The following is a description of a gene set: Genes with promoters bound by FOXP3 in unstimulated hybridoma cells. Foxp3+CD4+CD25+ regulatory T (T(reg)) cells are essential for the prevention of autoimmunity. T(reg) cells have an attenuated cytokine response to T-cell receptor stimulation, and can suppress the proliferation and effector function of neighbouring T cells. The forkhead transcription factor Foxp3 (forkhead box P3) is selectively expressed in T(reg) cells, is required for T(reg) development and function, and is sufficient to induce a T(reg) phenotype in conventional CD4+CD25- T cells. Mutations in Foxp3 cause severe, multi-organ autoimmunity in both human and mouse. FOXP3 can cooperate in a DNA-binding complex with NFAT (nuclear factor of activated T cells) to regulate the transcription of several known target genes. However, the global set of genes regulated directly by Foxp3 is not known and consequently, how this transcription factor controls the gene expression programme for T(reg) function is not understood. Here we identify Foxp3 target genes and report that many of these are key modulators of T-cell activation and function. Remarkably, the predominant, although not exclusive, effect of Foxp3 occupancy is to suppress the activation of target genes on T-cell stimulation. Foxp3 suppression of its targets appears to be crucial for the normal function of T(reg) cells, because overactive variants of some target genes are known to be associated with autoimmune disease. studied in species Mus musculus from publication Marson A, Kretschmer K, Frampton GM, Jacobsen ES, Polansky JK, MacIsaac KD, Levine SS, Fraenkel E, von Boehmer H, Young RA (PMID 17237765) Human Gene Set: MARSON_BOUND_BY_FOXP3_UNSTIMULATED, and this is the list of marker genes: ERN1, EAPP, CENPK, FLAD1, AP4M1, TAPT1, ZPBP, PLEKHF1, EVI2A, ANKZF1, SLC16A6, PKN2, KCNA3, HPGDS, COPG1, XPO1, NR1D1, P2RY10BP, MAP3K1, DPH6, CX3CR1, H2AC25, HNRNPF, BASP1, PSMD8, AOX1, TFB2M, SMPD2, HMG20A, WDR44, NAA16, C11orf71 (NCBI Gene Id 54494), APLP2, MSH3, FBXW10, POU2F3, PIAS4, PON2, NDOR1, CTSE, RMND5A, INSIG1, HMMR, TRIM33, SPACA4, AMPH, PDE12, CNPY2, CARTPT, KDM2B, JMJD6, IRAG2, GSR, OS9, FAM13B, SLC39A1, GGPS1, H3-4, PRCC, THA1P, ARID1A, MRPL45, MORC2, TNFRSF18, H1-4 (NCBI Gene Id 3008), IL17RA, POLR3B, CCR4, BLOC1S5, LDB1, CCDC18, WDR45 (WD repeat domain 45), PSME3IP1, PKN3, PAIP2B, ICAM2, TMEM134, LRRC66, INPP1, FRAT2, FAM185A, AMZ2, OAF, P2RY10, GARIN2, POGLUT3, SART3, ZNF394, NXT2, IL9, H1-5, DCAF1, PTTG1, ELOA (elongin A), OR2Y1, PHTF2, CERS2, PPP2R5A, MR1, PPP3CA, DENND1B, DBR1, NT5E (NCBI Gene Id 4907), SHROOM1, RAB18, CPD, IRF8, KPNB1, CRYBA4, SACM1L (NCBI Gene Id 22908), GGNBP2, OGT, GTF3C6 (NCBI Gene Id 112495), APLF (NCBI Gene Id 200558), KHNYN, H2AC8, H4C9, RAG1, STAP1 (signal transducing adaptor family member 1), ARL4A, NDFIP1, PANX1, IRF4, FBL, ASB3, H3C15, PRR15L, SLC25A24, FBXO46, KIF11, NHLRC2 (NCBI Gene Id 54835), TMEM62, UBAP2L, UBL3, DCK, TCTA, PLSCR1, RLBP1, OTUD5, ELK4, LPCAT3, ANAPC16, MINDY1, TOR1AIP1, YES1, CD226, WDCP, CPA3, TMEM91 (transmembrane protein 91), STAT6, H4C14, H4C8, STK4, LY9, ANAPC5, OGA, RBPJ, TMPO, DUSP10, RTN4IP1, ANXA9, CENPC, SLFN5 (schlafen family member 5), DARS1, ZNF275, TERF1, SH2D3C, RAMP1, HADHA, RPS29, BSPRY, ISCU, DNTT, GPX2, NYAP1, ING3, AKIRIN1, FRG1, HELZ, TMEM59, EGR2, SERTAD1, EMP1, MPP2, FANCI, SERTAD3, ARHGAP1, NUP153, ACTRT3, PRPF18 (pre-mRNA processing factor 18), MFSD4B, ANXA7, CNTF, H3C11, NSMCE1, PPWD1, SRSF1, DNAI4, LYSMD1, RGS9BP, POU2AF1, POLE4, H3-3A, AP2A2, DNAAF11, NIF3L1, NIPA1, LIN28A, CGRRF1, TTK, PLXNC1, TRIM5, METTL5 (methyltransferase 5, N6-adenosine), LBR, SEPTIN6, FDXACB1, GOLPH3, COPS7B, ZNF35, TBRG1, KIAA1143, SLC30A7, PSMC3, MARCHF6, KCTD2, DUT, NAA15, ATP1A2, ARPP21, ZPBP2, MINDY3, DDB1, XRCC4, PTGIR, GGTA1, CPNE7, LEO1, BBS4, PABPC1, GPR18, KDM5C, PCMT1 (NCBI Gene Id 5110), KLRB1, PRPS1, CNOT6L, ARHGAP10, ELP3, TMEM164, PRMT5, NMI, DGKA, UBE2W, TRPC4AP, MAPKAPK3, TIMM22, DCLRE1A, ITGAL, CXCR6, SYTL1, GFPT1, STAT3, GLB1, CWF19L2, MBD4, UBB, RAD1, CPT1A, MANBA, H2BC7, TMEM106B, RASGRP4, KIF18B, ECH1, GIMAP5, NUDT4, AQP11, TEC, H2AC4, NANP, THYN1, SMYD3, GABARAP, ORAI2, CDC40, SESN1, WASF2, PYM1, CNOT2, ZNF609, BNIP2, PLGRKT, TMED5, PDK1, IMP3, TOM1L2, TAFAZZIN, ELL, PRUNE1, SSNA1, MBTPS2, PLEKHG6, AKT1S1, DUSP16, DYNLT4, NPAT, PIK3CD, ACAT1, ZFP1, LCP2, PTGR3, GRK6, MPLKIP, UBR1, RGS5, TP53INP1, VMP1, MAP3K14, OR7E24, NFE2L2, H3C8, RHBDD3, ZFP36L1, AMBRA1, UBE2H, DENND6A, TMC8, CLK1, SLU7, RPS6KA3, BLTP2, VAMP4, CFAP68, THEMIS, FTH1, NUF2, MDH1, EPS15, MRPL34, PNPLA7, CDK19, PYHIN1, SIRT1, PICALM, MRPS33, PHF6, STK26, SPPL2A, GIMAP6, UFC1, PPP4C, STOML1, CEP57L1, PIGK, LZTFL1, FNTB, NKAP, MYC, PDCD1, UBA6, CR1L, CPSF2, KIF5B (NCBI Gene Id 3830), SERPINA11, ABCA7, GLIPR1, PTPN22, ZBTB1, FCGR2A, PRDX1, RUNDC3B, CREB3L4, HIBADH, CTSS, TNFRSF9, F2RL2, PXMP4, RBM7, FKBP1A, MSGN1, AGGF1, ORC5, LRRC8C, ABCB6, PSEN1, HSPA4, RANBP2, VSIG8, TTC16, MGME1, ART2BP, VPS45 (NCBI Gene Id 11312), WBP11, LIMD2, RGS2, ISY1, GPR171, SIK3, RBM5, CLEC12A, TEX261, RPS26, BRMS1L, LAPTM5, ENOPH1, CCNY, ARID5B, ZNF708, ZDHHC9, CSTB, RHBDF1, BLOC1S6, WNT2B, STX12, RIC1, TRAPPC1, NUDT5, MAD1L1, BCL10, MOK, WDR20, LEPROTL1, ZDHHC17, MAP2K6, DHRS3, WBP2, TRAPPC2, LRRC41, TKFC (triokinase and FMN cyclase), PSMB11, RBM47, ZFAND6, FGD3, CABP1, MICAL1, KCTD10, PRDX6, AIMP2, STC2, KCNN4, ZMPSTE24, CCN2, SURF4, RPLP1, HNRNPL, SEMA4A, KDM5B, ECT2, WRAP53, ATG7, DDX42, MBP, PLEKHB1, POLN, RWDD1, ZNF879, MADD, HSP90B1, FAM149B1, CLCC1, ZBTB25, ETAA1, HAUS4, GRM6, PIKFYVE, EIF2AK3, POLR1E, MNS1, STRADA, ATG12, EXOSC4, TBC1D10B, CD3D, YLPM1, TMEM167B, H2BC18, MRPS31, SLC35B4, PSMB5, ARL4D, PKM, PODNL1, TCP11L2 (NCBI Gene Id 255394), LGALS8, FCRLA, ABHD12, CD3E, LRRC8D, IZUMO4, TSHZ1, UBE3B, KRI1, ARSB, LRRC75A, CSNK1A1, CENPL, PSMD4, TMEM60, TCF4, AK2, HADHB, ARID3B, RPS3A, TRPV2, VSIR, KCNJ2, SPATA6, PSD4, CGAS, TPP2, ATP5MG, DDIAS, RSRP1, H3C1, RIBC1, KIF23, ZC3HAV1, DNAJB4, DLX1, NPAS4, NXN, OSBPL8, CNPPD1, YWHAZ, UBXN8, ARHGAP11A, PRTN3, EIF2S1, SPTY2D1, PPP1CB, VPS37B, ACBD5, ATXN1, MTO1, CCPG1, NDUFB3, UBE2D3, SP6, DCLRE1B, PIGL, ATM, LAS1L, GNG2, TCEANC2, ITPRIP, STX1A, MRNIP, H3-3B, CCR8, DDIT4, HYCC2, GIMAP4, MCM7, E2F2, NPTN, CD48, AMDHD1 (NCBI Gene Id 144193), ADORA2A, H2AJ, CDK17, LRRC42, ELOVL5, CLTC, NUP62, MYNN (NCBI Gene Id 55892), H2AC7, DNAJC1, ADH1A, METTL21A, NEMF, PITPNB, ATF5, SPAG6, MNT, DAP, PRPSAP1, FSCN2, ITK (IL2 inducible T cell kinase), NF2, PCNX3, TMEM50A, PSMA3, TESK2, SARAF, SLC6A4, DUSP6, PIK3CG, SLX9, KLF6, ARHGDIB, H4C1, SUMO2, H3C13, SERPINB7, HERC1, ABT1, LRP10, TOP2B, CCDC77, EVI2B, MLH1, CYSLTR1, MTFMT, HIVEP1, SHARPIN, STKLD1, TUBA8, CD274, TIPARP, MYL11, FGFR1OP2, DIPK1A, VEZF1, REST, JAK2, DMAC1, SLC22A4, SEC14L1, EID1, VTA1, RHEB, SEPHS2, PPP2R5C, KRR1, TBC1D15, CCDC28A, ZKSCAN5, MAP2K2, DOHH, FKBP1B, RCC2, FGL2, TTC5, ATP5PD, GPR146, SLC25A40, FYB1, PTPRC, H1-6, CDC27, NFKB1, ST6GALNAC1, SNX31, GTF2A2, TEX19, COX11, MAPRE2, ARL6IP6, CRACDL, ARL4C, MACROH2A1, DYNC2I2, UBALD2, SMC1A, COX20, MOXD2P, EOLA1, ZNF280D, MIB1 (NCBI Gene Id 57534), B9D2, IFI27, ARID5A, SMG9, CFAP43, IFT122, SLC26A11, TXNL4B, RNASEK (ribonuclease K), WDR26, EIF3H, APEX2, JUNB, GTF2B, EDEM1 (ER degradation enhancing alpha-mannosidase like protein 1), CISH, GPAA1 (NCBI Gene Id 8733), ASF1A, GBP2, SNX12, TES (NCBI Gene Id 26136), TNPO1 (transportin 1), ARL15, MKNK1, RETREG2, DRC3, HNRNPUL1 (NCBI Gene Id 11100), TOR4A, RDM1, H4C3, SGSH, TPRN, MPG, MTRF1, WBP1, CDKL3, EIF1, MED16, TRIM8, CD84, EGLN1, HSPA9, F12, LSM5, EPC2, STX7, IFT46, POLR2A, USP6NL (NCBI Gene Id 9712), WDR31, TRPA1, ARF6, SRP54, MINK1, ACTR2, TMEM222, CHEK1, DDA1, NCAPD3, ERCC3, ZNF280B, H4C4, TXNIP, UBE2B, CSNK1G2, SLC4A1AP, METTL27, ME2, POLDIP2, AVPI1, RETREG3, TRIM16, H2AC18, KIF3A, GNA13, GLT8D2, UNC5A, GGT1, ENTPD5, USP3, C1orf74, SLC37A3, ST8SIA4, GPD2, SIAE, H2BC5, TPGS2, CHORDC1, ARHGEF12, FBXL3, CD28, RASA3, FAM117A, TUBB4B, ADD1, NRDC, TBL1X, EFCAB9, ELANE, ABHD8, PRPF40A, CA12, GPR22, OSTF1, DHFR, RDX, LYSMD3, PES1, NDUFS4, RNMT, CDC123, HNRNPU, USF1, HMGB1, CCNI, JAML, CAT, MAP3K20, LDLRAD3, ELF1, ATP6V1D, ARMC6 (armadillo repeat containing 6), DCLRE1C, GATA3, STK10, AGO2, STXBP4, VPS11, ZWINT, CDK9, USP48, NSUN4, SUPT7L, OR10S1 (olfactory receptor family 10 subfamily S member 1), PRAF2, MLEC, RBKS, TTLL6, NASP, LMAN2, MED1, SCMH1, NUMA1, TAT, H4C6, EEA1, SCNM1, CCDC38, GMFB, PPP1R13B, ANGEL2, GDI2, ATF7IP, NEDD9, FHIP1B, ACTR3, MDM4, DDB2, ME1, CREB1, POT1 (NCBI Gene Id 25913), RMND5B, CCNG2, COQ8A, ATP10D, WEE1, CAMK1D, TNFRSF1B, NFIA, DAPK3, LDLRAP1, KTI12, FYN, MS4A6A, ELAC1, CENPA, ALG9, RHOA, WASF1, P2RY14, MAF1, RFX3, PPIL3, PTK2, CD53, TMEM203, TRDMT1, IBA57, SMAD3, BTNL10P, URM1 (NCBI Gene Id 81605), TMEM147, DHX33, DMWD, SSBP3, SETD5, MPHOSPH8 (M-phase phosphoprotein 8), DMPK, AQP9, LRRC75B, POU3F3, SASH3, RIPK1, TUBG1, LIF, ARMC8, GOLPH3L, ZFAND5, CREBL2, TPST2, CITED2, ACAD8, UBA3, ABHD2, TMIGD1, RTF2, MRPL48, EDARADD, NKX2-6, SFT2D2, MRPL33, HNRNPDL, SETDB1, SLC25A45, NCOA3, ITM2B, PIK3IP1, NUP43, SPA17, EMP3, ANKRD22, KDM5A, LYSET, LRR1, CBLN3, PSMC1, ARG2, ZNF146 (NCBI Gene Id 7705), TMC6, SLC17A5, FUBP1, C16orf87, CCND2, SYPL1, ZEB1, IFIT2, TRAF3IP2, ASCC1, PNKP, H2AC19, GINS1, ZAP70, ITGB3BP, SUGCT, DHX38, H2BC13, LYRM4, URI1 (URI1 prefoldin like chaperone), AJUBA, GRB2, ACSL4, PML, SYNE3, DNAJB6, ATG13 (NCBI Gene Id 9776), SLC35D1, BLM, DDX24, LSM3, CREB3L3, PRPF8, ST3GAL4, R3HDM1, PJA1 (praja ring finger ubiquitin ligase 1), ZER1, HSPH1, TGFB1, SHMT2, DARS2, HERC3, PYGL, STX16, DNMBP (NCBI Gene Id 23268), ARHGAP12, PPP5C, RBL1, EIF5, PMS2, UBE2R2, DOK2, IDH1, HAUS6, DYNC2I1 (dynein 2 intermediate chain 1), SF1, KPNA3 (karyopherin subunit alpha 3), MINDY2, EEF2, MOV10, PHF23, PLEKHS1, WAC, DNAJB12, SMARCC1, RBM6, TBC1D17, TENT2, TSC22D3, VEZT, SUPV3L1, CRYGD, PARK7, PRKAR1A, IL10RA, PDE7B, LAMTOR1, PRELID3A, MSH6, ELAVL1, CTDSP1, FOSL2, PTPN2, MOB1A, SHISA5, NGLY1, MFSD6, CUL3, FGD6, MLLT3, ANKRD13C, MED24, TNFRSF19, C17orf49, CAMK2D (NCBI Gene Id 817), CD276, BRIX1 (NCBI Gene Id 55299), SLC39A3, CDK5RAP3, MAP4K1, FLI1, POLG2, MTHFD2, PAQR7, CYTIP, ZRANB3, UTP23, LSM14A, EXTL2, KDM6A, ETV3, PCBP1, NAT9, PPP2R2A, HHAT, STK11IP, NQO2, ANKMY2, CAB39, SHC1, MIER1, SEPHS1, DET1, CD3G, TJP1, HARBI1, LRRC10, RNF38, NDUFC1, SLC23A3, MFSD11, H4C16, JUND, TTC41P, SLC2A8, CDKN2D, UBE2V1, PLPPR3, CLEC2D, FRMD8, BZW2, PPT1, YTHDF3, TXN, FOXO3 (forkhead box O3), MAP4K4, AURKB, XPO7, ERI2, C1orf43, H2BC6, MYO1E, SYT3, ITCH, HAUS3, TMOD3, NCOR1, RIMOC1, TMEM199, TRA2A, MEF2A, CMTM6, RAB2A, TRAIP, MCM3, GIMAP1, SLC25A37, ERAP1, TOR1AIP2, H2BC11, RIOK1 (RIO kinase 1), ZBTB5, RAD52, PDCD6IP, NPB, UVRAG, HERC4, FYCO1, XCL1, ITGAV, SLC25A15, KISS1R, GCNT3, ZNF595, METRNL, NME1, SMAP2, UQCRH, NAIF1, TPM4, MAP3K11, LPXN, MYL6B, KNL1, TGFBR2, SMAD7, GMDS, PDE6D, ETS1, NFATC3, XBP1, SRGN, NUP35, RNF128, CSTPP1, ATP6V0A1, SRP19, AP4B1, ARHGEF6, OACYLP, EIF3K, FOSB, DBF4, LY96, SLC9A9, IGSF8, SEC11A, ATP2A1, H3C14, CENPM (centromere protein M), TSC22D4, RGS14, RAB19 (RAB19, member RAS oncogene family), B4GALT1, GJA1, SYTL2, ERLEC1, VTCN1, TMEM140, UTP6, RHOB, ATOSA, GARS1, ARHGAP15, JARID2, CSK, DEGS2, LRP2BP, MAT2B, RSPRY1, ACTG1, CYP1A1, SCML4, ANKRD61, GNGT2, ARHGAP45, XPA, MOB3A, ARIH1, USP21, MEIG1, TLE3, TMEM71, ALDH3A2, SGPP1, RMC1, ZBED5, KAT6B, TP53, CEP120, SUB1, ARL6IP5, AFG2B, PEAK1, EIF4EBP2, RGS1, FZR1, ID2, PTPRJ, NMRK1, RPL29, ITGA9, NABP1, TOMM34, SRPK2, GPR82, MMP9, VSTM2L, CDKN1B, C12orf60, ALYREF, SNHG16, ZNRF2, WDPCP, PAPLN, NCAPD2, TAX1BP1, EFCAB2, FAM98B, BABAM2, C15orf48, NPC1, TMEM30A, CDK11B, PRRG4, MBNL1, HBP1, KIF15, FZD7, CCDC47, RPS6KA5, TMED10, HP1BP3, MAPK6, NUDCD2, MCM10, MIS18BP1, SLC22A5, GEN1, TNFSF4, USP4, FARS2, EWSR1, SYF2, PGAM1, RBL2, EIF4E3 (eukaryotic translation initiation factor 4E family member 3), SLC17A6, CAGE1, QPCTL, OPLAH, GPR65, TPRG1L, ARCN1, SESTD1, MTG1, KCNAB3, DNASE1L1, INTS13, FBRS, TMEM167A, SLC20A1